Given this list of marker genes NPDC1, SGCB, RRM2 (NCBI Gene Id 6241), UBE2C, TMEM97, HK1, RBM28, IL17RB, H4C2, USP24, GLIPR1, CCL24, MTMR2, CCL19, MELK, PLA2G15, AGK, FBL, IGLV1-44, GINS2, GPA33, ATP5MC2, AURKB, EIF4E2, CCNB2, HMOX2, CPEB1, ZWINT, SNX2, SLC2A5, SMS, CD93, QDPR, CCL13, MZF1, GALNT3, HTRA2, AP3B2, STK39, EMC9, PARP2, ZNF682, RACGAP1, RNF5, RAD51AP1, ZBTB6, NUSAP1, CDC25B, TBC1D22A, CTPS2, COTL1, ESPL1, MRTO4, MKI67, MYG1, CCR8, EMP3, COL6A1, KIF2C, LANCL2, SLCO2B1, IGLL3P, JPT1, RHOBTB1, HYAL3, CCL23, TTK, ABCG2 (ATP binding cassette subfamily G member 2 (JR blood group)), AGBL5, ATP5MF, MCM6, TMEM258, OIP5, UROS, TMEM106C, TYMS, SHMT1, MYH6, HMGB2, MCM2, AKR1C1, CYREN, TTC31, PCCA, KIF11, HNRNPA3P1, BIRC7, E2F8, ARHGDIB, TPST1, EPB41L2, CAPN10, UQCRQ (NCBI Gene Id 27089), FANCI, ABCC5, TK1 (thymidine kinase 1), BLMH, TAS2R10, PSME4, CDK1, GGH, TUBB, AP1S2, CASD1, DTL, IL1R2, AKR1A1, WNT5B, NEFM, ALOX12, SNRNP25, CFP, KDM1A, SYNGR2, STAB1, OSGEP, TUT4, CCL17, HMMR, WNT5A, ASL, PIP4K2B, HSPA1A, RPS16, BIRC5, IDH2, DHCR7, RASSF2, CUL9, UROD, NCAPG, TPX2, STMN1, CCL18, APCS, DTYMK, TCF4, CBX5, CDCA8, CEP131, CDKN3, PTTG1, MNAT1, TUBB4B, BUB1B, AKT2, KIF20A, NDUFA1, RGL1, CTSH, SEMA4D, CHEK1, DLGAP5, SLC25A13, TRIM14, ARPC3, DHFR, PLAAT3, COCH, MARCO, EPRS1, ITGA4, PLK4, MAGED1, PLAU, ACAT1 (acetyl-CoA acetyltransferase 1), NDUFA7, CCNB1, CCDC28B, GALT, TDP1, PPA2, ETNK2, FEN1, NDUFB1, SPAG5, CCNA2, BCAS3, NDUFB8, POLE2, NEDD8, MYB, KIF15, LMCD1, PCLAF, SEC13, HOMER2, IL21R, BAX, CDC20, MS4A6A, HS3ST2, EMC6, COBL, MYO6, C19orf53, KIF23, UCP2, here is a description of the gene set: CD25+ regulatory T cells develop in the thymus (nTregs), but may also be generated in the periphery upon stimulation of naive CD4 T cells under appropriate conditions (iTregs). The mechanisms that regulate the generation of peripheral iTregs are largely unknown. We used microarrays to gain insights into the molecular program of extrathymic Treg development. Human Gene Set: GSE24634_IL4_VS_CTRL_TREATED_NAIVE_CD4_TCELL_DAY7_UP species: Homo sapiens Genes up-regulated in comparison of CD25- T cells treated with IL4 at day 7 versus untreated CD25- T cells at day 7. from publication Prots I, Skapenko A, Lipsky PE, Schulze-Koops H (PMID 21347372)